The following is a description of a gene set: species: Homo sapiens Increased intensity of the a reflex in the leg. Human Gene Set: HP_LOWER_LIMB_HYPERREFLEXIA Lower limb hyperreflexia, and this is the list of marker genes: CYP2U1, NR4A2, PSEN1, REEP1, ARL6IP1, MTPAP, FARS2, RARS1, CAPN1, GCH1, CLDN11, TRRAP, ERLIN1, LARGE1, IFRD1, WASHC5, IBA57, ALDH18A1, USP8, SDHAF1, VPS11, ATP13A2, PLXNA1, SELENOI, HARS1, VLDLR, KY, AFG3L2, MECP2 (methyl-CpG binding protein 2), TREX1, TMEM63C, KIF1C, HPDL, TSPOAP1, MT-TE, HEXB, UBAP1, SDHD (NCBI Gene Id 91899), MSL3, ANO10, SPTAN1, ZNF142, KIF5A, EBF3, ABCC9, FTL, DPM1, LYRM4, UFC1, UCHL1, APOE, TAF1, REEP2 (NCBI Gene Id 51308), ATL1, VCP, TH, PGM3, DLAT, KDM5C, UBE3A (ubiquitin protein ligase E3A), MTRFR, SPG11, MKS1, NONO, COX4I1, KPNA3, GLUL, AMFR, GJB1 (NCBI Gene Id 95372), SPG7, IMPDH2, SACS, ST3GAL5, SDHB, KIF1A, SIGMAR1, SLC33A1 (solute carrier family 33 member 1), OCA2, U2AF2, COQ4, PNPLA6, SDHA, SUMF1, DKK1, ZFYVE26, NIPA1, PDE8B, LBR, RUBCN, SYNE1, TNR